Given this list of marker genes IL7, RBM39, ASIC2, RAI1, MYCT1, FABP2, ZFPM1, LMO2, MSX2, SORCS1, ISL1, VAMP1, CTNNA3, HS3ST5, KCNJ13, PLAG1, CREB5, KLF14, SCUBE3, ACTC1, CHCHD7, HTR3B, NRP1, SRPK2, MBNL2, MTMR10, RSPO2, DMD, CACNA1D, FHL3, PTGDR2, ADPRHL1, RUNX1T1, HNF1B, DCAF11, UBXN10, PLAC1, SPINK4, SIX1, IPCEF1, TSHB, TSC1, HOXA3, LIX1, NCDN, TMEM47, HOXA1, FAM91A1, NRAS, ADAMTS3, UBE2K, ESRRG, ZFPM2, LUC7L3, BMP10, TDRD5, IL4, PPARGC1A, here is a description of the gene set: Genes having at least one occurrence of the motif AGATAAGATAA in the regions spanning 4 kb centered on their transcription starting sites. This matches the EVI1 transcription factor binding site V$EVI1_03 (v7.4 TRANSFAC). Human Gene Set: EVI1_03 species: Homo sapiens